Given this list of marker genes IKBKB, NFKBIA, TBK1, RIPK3, NKIRAS2, DHX9, DTX4, RIPK1, IKBKG, CHUK, NFKB1, IRF3, TICAM1, RELA, ZBP1, NLRP4, NKIRAS1, TLR3, NFKB2, MYD88, NFKBIB, here is a description of the gene set: Human Gene Set: REACTOME_ZBP1_DAI_MEDIATED_INDUCTION_OF_TYPE_I_IFNS species: Homo sapiens ZBP1(DAI) mediated induction of type I IFNs